The following is a description of a gene set: species: Homo sapiens Any process that modulates the frequency, rate or extent of amyloid fibril formation. Human Gene Set: GOBP_REGULATION_OF_AMYLOID_FIBRIL_FORMATION, and this is the list of marker genes: CLU, TREM2, APOE, MIR31, LDLR, PFDN5, APP, PFDN6, CRYAB, IAPP, PFDN2, HSPG2, PSEN1, PFDN1, USP8, VBP1, CHRNA7, PFDN4